The following is a description of a gene set: Human Gene Set: WP_TRANSCRIPTIONAL_CASCADE_REGULATING_ADIPOGENESIS Transcriptional cascade regulating adipogenesis studied in species Homo sapiens, and this is the list of marker genes: KLF15, GATA3, CEBPG, EGR2, KLF5, GATA2, CEBPB, CEBPD, CEBPA, SREBF1, KLF2, PPARG, DDIT3 (DNA damage inducible transcript 3, NCBI Gene Id 92982)